Given this list of marker genes Tex261, Nat8f5, Cct7, 1700003E16Rik, Nat8f7, Figla, 5430434F05Rik, Gm10445, Clec4f, M1ap, Gm22893, Mir7232, Eva1a, Gm15624, Gm7507, Cyp26b1, Npm3-ps1, Gm20383, Bola3, Htra2, Cd207, Slc4a5, Zfp638, Ctnna2, Mob1a, Spr, Nat8, Nat8f3, Ccdc142, Ptges3-ps, Gm38840, Pcgf1, Gm18537, Hk2, 2310069B03Rik (NCBI Gene Id 69652), Pradc1, Gm44240 (NCBI Gene Id 115490415), Gm18290, Mir6374, 1700009C05Rik, Gm6312, Tacr1, Gm5878, Gm7424, Reg3d, Fbxo41, Add2, Ccdc142os, Dok1, 1700097M23Rik (RIKEN cDNA 1700097M23 gene), Mir7040, Tlx2, Paip2b, Wbp1, Noto, Smyd5, Dysf, Gm20362, Gm5311, Gm21045, 4930504D19Rik, Nat8b-ps, Gm7542, Reg3g, 6330415B21Rik, Reg1, Emx1, Gm25818, Atp6v1b1, Nagk, Nat8f2, Reg3a (regenerating islet-derived 3 alpha), Gm6072, Exoc6b, Mrpl53, Gm7443, B230319C09Rik, Gm21392, Gm23014, Vax2os, Reg2, Gm21284, Dguok, Pole4, Mir705, Alms1-ps1, Dctn1, Lrrtm1, Gcfc2, Alms1-ps2, Gm4409, Gm26264, Egr4, Sfxn5, Lrrtm4, Gm32591, Tet3, Loxl3 (NCBI Gene Id 16950), Reg3b, Gm7498, Mtrnr2l7, Gm6261, Gm5138, Mir468, Mogs, Ino80b, Gm38843, Dqx1, Gm33024, Gm4874, Gm38839, Gm5312, Gm20371, Gm19287, Spr-ps1, Gm19265, Ankrd53, Alms1 (ALMS1, centrosome and basal body associated), Gm10444, Tprkb, Gm31861, Mrpl19, Lbx2, Nat8f1, Gm22530, Gm43309, Rab11fip5, Stambp, Gm5576, Nat8f4, Aup1, Sema4f, Gm25054, Rtkn, Dusp11, Actg2, Mthfd2, Nat8f6 (NCBI Gene Id 100504710), 1700124L16Rik, Gm6342, Wdr54, Vax2, here is a description of the gene set: studied in species Mus musculus Mouse Gene Set: chr6C3